Given this list of marker genes IFT43, CLUAP1, WDR19, TTC21A, IFT140, WDR35, TTC21B (tetratricopeptide repeat domain 21B), IFT122, here is a description of the gene set: studied in species Homo sapiens Human Gene Set: GOCC_INTRACILIARY_TRANSPORT_PARTICLE_A The smaller subcomplex of the intraciliary transport particle; characterized complexes have molecular weights of 710-760 kDa.